Given this list of marker genes Ctla2a (NCBI Gene Id 13024), Kifc1, Hba-a1, Adam19, Gstk1, Fmo1, Klf1, Creg1, Cd93, 0610010K14Rik, Kpna1 (karyopherin subunit alpha 1), Sox18, Psme1, Bcl6b, Hbb-bh0, Raly, Dctpp1, Brk1, Mea1 (male enhanced antigen 1), Lig1, Slc39a8, She, Igf1, Lmnb1, Actc1, Gfi1b, Sar1b, Stab1, Reep6, H19, Fxn, Rnf149, Eng, Angpt2, Jkamp, Med1, Polr2j, Flt4, Csnk2a1, Mbp, Gdap2, Rhag, Epb42, Pttg1, Net1, Daxx, Tom1l1, F10, Cavin1, Tlcd4, Arl6ip5, Tfpi, Ell2, Pip4k2c, Lpl, Ramp2, Cldn5, Mrpl58, Tmed4, Nfatc1, Hbb-bs, Gstm2, Slc4a1, Ifitm3, Smim1, Acp1, Bmp2k, Gata1, Actb, here is a description of the gene set: from publication Guo Y, Chan R, Ramsey H, Li W, Xie X, Shelley WC, Martinez-Barbera JP, Bort B, Zaret K, Yoder M, Hromas R (PMID 12791650) Mouse Gene Set: GUO_HEX_TARGETS_DN species: Mus musculus Genes down-regulated in day 6 embryoid bodies derived from embryonic stem cells (ES) with HEX knockout. The first hematopoietic and endothelial progenitors are derived from a common embryonic precursor termed the hemangioblast. The genetic cascades that regulate the differentiation of the hemangioblast to hematopoietic and endothelial cells are largely unknown. In general, much of embryonic development is coordinately regulated by temporal and spatial expression of transcription factors, such as the Homeobox (Hox) gene family. We and others isolated a divergent homeobox gene termed Hex (or Prh) that is preferentially expressed in hematopoietic and endothelial cells. Using in vitro Hex-/- embryonic stem (ES) cell differentiation, in vivo yolk sac hematopoietic progenitor assays, and chimeric mouse analysis, we found that Hex is required for differentiation of the hemangioblast to definitive embryonic hematopoietic progenitors and to a lesser extent endothelial cells. Therefore, Hex is a novel regulator of hemangioblast differentiation to hematopoietic and endothelial cells.